Given this list of marker genes PYCARD (PYD and CARD domain containing), IL1B, MEFV, CASP1, IL18, here is a description of the gene set: species: Homo sapiens Pyrin inflammasome signaling pathway. Pathway ID: N00868. Pathway type: Reference. Pathway class: nt06521 NLR signaling. Pathway Definition from KEGG: (MEFV+PYCARD) -> CASP1 -> (IL1B,IL18) Human Gene Set: KEGG_MEDICUS_REFERENCE_PYRIN_INFLAMMASOME_SIGNALING_PATHWAY